Given this list of marker genes BCL11A, CLEC4D, CD68, HCK, CCL5, ACSL1, RAB31, ASAH1, GATA2, SERPINB1, CD151 (NCBI Gene Id 977), PLA2G15, CEBPB, GABARAPL1, ATP13A2, TLCD2, SPSB4 (NCBI Gene Id 92369), TTC39C, GCNT2, NCF1, TNFSF14, PCTP, PTPRE (protein tyrosine phosphatase receptor type E), S100A6, ANXA1, ABCB4, PLEK, NAPSA, CAB39L, PTK2B, EIF2AK4, DEPTOR, OGFRL1, TSC22D1, CD9, IER3, MGAT4B, PAK1, PTGER3, CA2, LUZP1, LACTB, ABCC1, CD34, FFAR2, PTER (phosphotriesterase related), ITIH5, SHISA2, IGDCC4, SH2D3C, CCND1, ECI1, THEMIS2 (thymocyte selection associated family member 2), DENND5A, OTULINL, CD180, HBEGF, DYRK3, RNH1, CNN2, GSN, LITAF, GCSAM, AQP9, GNA15, PLXNB2, CD300A, NIBAN1, SKAP2, FCGR2A, RFLNB, LPCAT1, RHOQ, HHEX, P2RX4, CDH17 (NCBI Gene Id 1015), MGST1, FES, GLUL, TMEM51, IRF6, SIRPA, FLNA, KRT7, SELENBP1, CD81, APPL2, APP, SPTLC2, ARL5A (NCBI Gene Id 26225), ARHGAP6, DOCK7, MYADM, MPO, PLXNC1, DOCK5, GKAP1, RRAS (NCBI Gene Id 6237), ZNF768, S100A4, GGH, NEK6, PRCP, RIPOR1, CYFIP1, MAPRE2, HNF4A, NRGN (NCBI Gene Id 4900), RAB32, EBI3, BTK, ACVR1B, KCTD12, SIRT3, PKIB, UAP1L1, ITGAX, ST3GAL2, TCEAL1, STAU2, LRRK1, CTBP2, CKAP4, PRTN3, LTB4R, FCGR2B, DUSP6, TUBB6, MANBA, CEACAM21, MYCN, IL10RB, FHOD3, DYM, RORA, LTF, SASH1, CD44, SLC35F5, C1orf54, NFAM1, CD33, KCTD14, SPNS2, IRF5, GLIS2, CD52, VCL, SERF1A, ANGEL1, TJP1, RASGRP2, SPI1, KLRD1, SEPTIN2, TYROBP, FGD2, LBP, IL4R, TMEM205, PLA2G4A, TMEM40, B4GALT6, PTPN12, TAGLN2, GP9, LMO1, CST3, WDFY3, TMBIM1, FASLG, CLNK, TTPA, CPPED1, TSPAN4, SORL1, CABLES1, FBXO33, MEF2C, C11orf54 (NCBI Gene Id 28970), TSPAN32, GGT5, CSF1R (NCBI Gene Id 8156), CD244, HIP1R, NR2F6, RAI14, GPR65, SMAD6 (SMAD family member 6), RNF149, RGS1, TNIP2, ARHGAP12, HSD17B11, PROCR, HYCC1, GSTM3, KLHDC2, CALHM2, RAMP2, here is a description of the gene set: species: Homo sapiens Genes up-regulated in comparison of thymic progenitors versus DN3 thymocytes. Human Gene Set: GSE24142_EARLY_THYMIC_PROGENITOR_VS_DN3_THYMOCYTE_UP Development of T-cells provides a unique opportunity to study cell-fate determination due to the accessability and the well defined stages of developmental stages. In order to understand the genetic programs underlying fetal and adult T‑cell fate specification we subjected highly purified fetal and adult T-cell progenitor populations to a genome‑wide transcriptional analysis. The aim was to identify molecular elements that govern T-cell fate specification as a whole but ultimately to isolate elements that were specific for a given population in a specific developmental window. from publication Belyaev NN, Biró J, Athanasakis D, Fernandez-Reyes D, Potocnik AJ (PMID 22581009)